The following is a description of a gene set: Reactome Pathway: CASP5 inflammasome assembly This event has been computationally inferred from an event that has been demonstrated in another species.<p>The inference is based on the homology mapping from PANTHER. Briefly, reactions for which all involved PhysicalEntities (in input, output and catalyst) have a mapped orthologue/paralogue (for complexes at least 75% of components must have a mapping) are inferred to the other species. part of: Non-canonical inflammasome activation species: Mus musculus electronically inferred by orthology from the curated human pathway, and this is the list of marker genes: Casp4